Given this list of marker genes SLC26A8, GABRG1, SLC1A4, BEST3, TTYH1, TTYH3 (tweety family member 3), SLC17A8, VTI1B, GLRA3, GABRR2 (NCBI Gene Id 2570), GABRP, CHRNA7, ANO9, NHERF1, GABRA2, SLC26A11, CLCA1, BEST4, BEST1, TTYH2, GABRA3, GABRE, MFSD8, SLC17A7, GLRA2, STX8, APOL1, NMUR2, PACC1, SLC17A6, CLCN1, CLIC4, GABRQ, GABRD, FXYD1, CLCN2, CLCN6, ANO10 (anoctamin 10), GABRA5, CLCA4, GLRA1, SGK3, ANO1, CLDN17, CLCN4, GABRA4 (NCBI Gene Id 2557), CLIC2, CLIC3, GABRR3, CLCA2, STX1A, AQP6, GABRG2, CLCN5, SLC26A7, TMC4, CLDN4, VAMP8, GABRA1, SGK1, C8orf44-SGK3, GABRB3, SLC26A9, FXYD3, SLC26A6, GABRA6, CLCN7, ANO2, ANO8, STX7, GABRB1, GABRR1, BSND, OCA2, CLCNKA, CLCNKB, CLCN3, ANO6, BEST2, CLIC1, ANO7, CLCC1, ANO4, ANO5, SLC1A7, CFTR, GLRB, GABRG3, GABRB2, CLIC5, ANO3, CLIC6, here is a description of the gene set: Enables the energy-independent facilitated diffusion of a chloride ion through a transmembrane aqueous pore or channel. Human Gene Set: GOMF_CHLORIDE_CHANNEL_ACTIVITY species: Homo sapiens